The following is a description of a gene set: Genes predicted to be targets of miRBase v22 microRNA mmu_miR_654_5p in miRDB v6.0 with MirTarget v4 prediction scores > 80 (high confidence targets). species: Mus musculus from publication Chen Y, Wang X (PMID 31504780) Mouse Gene Set: MIR_654_5P, and this is the list of marker genes: Triap1, Sh3gl3 (SH3-domain GRB2-like 3), Fermt1 (NCBI Gene Id 241639), Tpm1, Ist1, Zfp583, Tra2b, Snx22, Sntb2, Unc5d, Atp2b1, Zfp507, Cd34, Rasa2, Cdyl2, Srsf6, Cdkn2aip, Zfp703, Zfx, Polb, Arpp19, Alas1, Fermt2, Glra2, Stag2, Prkar2b, Snai2, Lratd2, Psma6, Rala, Perp, Ica1l, Il1rl1, P2ry4, Pate4, Unk, Ipo4 (importin 4), Zfp367, Tbx4, Slc29a3, Zfp384, Nf2, Hmx3